Given this list of marker genes Adam1b, Ct55, Ctnnb1, Piwil4, Spem1, Rnase9, Meiosin, Mfsd14a, Prss43, Nanos3, Ska1, Mir449b, Pcyt1b, Drc1, Slc26a6, Pdilt, Amh, Ddx25, Rfx2, Crkl, Gm20843, Xlr4c, Bcl2, Ehmt2, Gnasas1, Gm1993, Gm10488, Lztfl1, Tug1, Inhbb, Tdrkh, Spata25, Hsf1, Pla2g4a, Zfp830, Ubr2, Bcap31, Wdr48, Bsg, Ednra, Armc3, Gm21294, Patz1, Ift20, Fxr1, Mov10l1, Gm2012, Txndc2, Cabyr, Sebox, Cntln, Gm20824, Eed, Rnf151, Catspere1, Hoxa10, Tmem203 (transmembrane protein 203), Eif2s2, Gm21760, Crtap, Tsix, Ybx2, Nr6a1, Catsperz, Cfap97d1, Sox17, Nr5a2, Ap3b1, Usp26, Serpina5, Fbxo24, Tspan8, Pou4f2, Nr0b1, Stau1, Majin, Sox3, Dnah1 (NCBI Gene Id 630521), Wdr77, Mns1, Efcab9, Wnt4, Nectin2, Ccdc33, Pafah1b3, Ropn1l, Bax, Afp, Zscan2, Pgr, Mycbpap, Lrrc46, Gm28961, Oca2, Slc4a2, Bmp8b, Sycp2, Yif1b, Prss37, Marf1, Hadh, Gorasp2, Spag8 (sperm associated antigen 8), Tut7, Cldn11, Golga3, Alkbh5, Tesk1, Bcas2, Asz1, Garin2, Ncaph, Ghsr, Gm21095, Cetn2, Morc1, Ift56, Nodal, Gm10230, Zfp541, Xrn2, Fmn2, Sohlh1, Xlr3c, Src, Igf1, Ttc12, Khdrbs1, Pabpc1l, Rbm46, Bmp4, Sstr1, Nanos1, Kit (KIT proto-oncogene receptor tyrosine kinase), Shb, Zcwpw1, Sec23ip, Kdm2b, Ctsl, Syce3, Celf3, Pik3ca (NCBI Gene Id 70742), Trim75, Sry, Shbg, Lrguk, Prmt7, Gal3st1, Tgfb1, Mael, Mcm9, Tle3, Prnd, Dnaaf3, Rhbdd1 (rhomboid domain containing 1), H1f7, Cadm1, Cip2a, Etv5, Cdc25c, Cabs1 (NCBI Gene Id 70977), Cit, Zmynd15, Ddx3y, Gm28102, Xlr3a, Pgm3, Trp63, Gata4, Mettl14, Sppl2c, Fkbp6, Pln, Stau2, Sod1, Epc1, Gopc, Semg1, Septin4, Cimap1a (NCBI Gene Id 69287), Smad5, Nup62, Gsr, Cntd1, Dicer1, Sgpl1, Foxj2, Tdrp, Tyro3, Ubb, Rab1a, Ndc1, Mcm8 (minichromosome maintenance 8 homologous recombination repair factor), Nppc, Abhd2, Bltp1, Klhl10, Adam7, Dhh, Rbx1-ps, AU040320, Pde4d, Txndc8, Rln1, Zdbf2, Prdm9, Atrx, Csnk2a2, Mecp2, Pxt1, Rad51c, Gm6121, 3830403N18Rik, Dpcd, Ggnbp2, Kcnq1ot1, Gm773, Cnbd2, Mtor, Oosp2, Mybl1, Meiob, Cib1, Airn, Cdkn1c, Spata2, Foxa3, Herpud2, Oas1d, Tle6, Zp3, Tcp11x2, Xlr4b, Six5, Dcaf13, Yy1, Gm21858, Mea1, Bik, Cylc2, Izumo3, Map7, Calr3 (NCBI Gene Id 76879), Hpgd, Axl, Npr2, Qki, Gm38999, Wnt3, Chn2, Axdnd1, Dld, Ube2b, Pnldc1, Sstr3, Psme4, Cfap119, Ptk2b, Ctcf, Ccr6, Clock, H2bc1, Ptx3, Tmprss12, Neurl1a, Adam24, H1f9, Hoatz, Clgn, Svs3a, Klc3, Tnfaip6, Gm20870 (predicted gene, 20870), Dhx36, Washc5, Odf4, Ccdc146, Meioc, Skil, Xlr4a, Fancl, Rgn, Zfp42, Spin2c, Armc12, Poc1b, Gm2030, Paqr5, Slc26a8, Mas1 (MAS1 oncogene), Kat5, Septin7, Sirt2, Arid4b, Dnali1, Mertk, Cylc1, Ythdf2, Mcmdc2, Sly, Kat8, Vps13b, Ttc21a, Pde5a, Tssk4, Rspo1, Garin3, Spdya, Syne1, Ihh, H3f3b, Dpy19l2, Catsper1 (NCBI Gene Id 225865), Adrm1, Il18, Ggt1, Smad4, Atp2b4, Cfap54, Slc25a31, Cfap206, C2cd6, Tnp2, Pias1, Cdc25b, Atp1a4, Vipas39, Spmip6, Igf2r (insulin-like growth factor 2 receptor), Lgr5, Slc26a3, Rimbp3, Tuba8, Septin2, H2al2a, Fancg, Inhba, Kif18a, Dnmt3a, Scmh1, Tcp11, Rnf2, Ccna1, Tslrn1, Agfg2, Gm21996, Ddx20, Spata24, Bbof1, Setx, Inpp5b, Insl6, Garin1a, Rara, Hsf2, Snrpa1, Tmem119, Spag4, Wt1, Tmem232, Pafah1b2, Immp2l, Akt1, Fndc3a, Tssk5, Xist, Cfap44, Tlk2, Dazap1, Spag6 (NCBI Gene Id 381350), Fancd2, Mir449a, Chtf18, Hoxa9, Krt9, Ccnb1, Dnd1, Strbp, Rnf8, Misfa, Gm28870, Ppp1cc (NCBI Gene Id 627816, protein phosphatase 1 catalytic subunit gamma), Nkd1, Cfap70, Adam25, Septin14, Gm5935, Racgap1, Gsk3a (glycogen synthase kinase 3 alpha), Garin4, Fst, Sun5, Cyp26b1, Herc2, Btg1, Atm, Zbtb16, Celf1, Mroh2b, Tsga8, Ift81, Prm3 (NCBI Gene Id 407832), Spata6l, Prkaca, Rai14, Ptch1, Mir449c, Zfp296, Spin4, Notch1, Actl7a, Tssk6, Ddias, Hsf5, Chd5, H1f6 (NCBI Gene Id 57283), Tut4, Slco4c1, Meg3, Usp42, Tesmin, Mta2, Spatc1l, Dnaja1, Txnrd3, Gm20911, Ttll5, Apob, Tex19.2, Agfg1 (ArfGAP with FG repeats 1), H2ax, Garin1b, Rec114, Zmiz1, Spata46, Herc4, Ttll1, Styx, Ctcfl, Lep, Spin1, Rbx1, Gm7958, Cep128, Larp7, Rsph1, Ccdc159, Asb17, Ace, Zfp39, Zscan21, Ttll3, Gm4297, Zglp1, Ccnb1ip1, Selenof, Sun1, Lgr4, Hspa1l, Pla2g3, Bcl6, Eqtn, Ska3, Gm20736, Uchl1, Dmrt1, Gm5934, Ythdc1, Ptgdr2, Zfp37, Armc2, Psma8, Ros1, Ccnyl1, Odf2, Tpgs1, Kctd19, Spef2, Ift27, Catsperg2, Tex15, Msh6, Spire2, Hexb, Lamp1, Hfm1, Acrbp, Ccin, Cfap61, Tex19.1, Gm29866, Fbxw11, Meikin, Gm20817, Brca2 (breast cancer 2, early onset), Sox9, Agt, Bcl2l11, Paip2, Acox1, Zmynd12, Hook1, Ska2, Ctdnep1, Ica1l, Gm29554, Zpbp2, Spag16, Gm20820, Gsk3b, Mei1, Hspa2, Tm9sf5, H1f1, Ankrd49, Ybx3 (NCBI Gene Id 56449), Zfp628, Shcbp1l, Hoxa11, Galnt3, Dmrtc2, Suv39h2, Pmfbp1, Fshb, Sfmbt1, Prss44 (serine protease 44), Rps6kb1, Arid4a, Tial1, Trp53 (NCBI Gene Id 22059), Fancf, Pcsk4, Dedd, Bsph2, Vdac3, Mast2, Cenpe, Mei4 (NCBI Gene Id 75033), Lin28a, Calr, Tbc1d20, Kdm5a, Mamld1, Cnr1, Morc2b, Dcaf17, Bmpr1b, Fbxo5, Aspm, Hmgb2, Prok2, Jam3, Adamts2, Nicol1, Rps6, Hps1, Nek1, Foxc1, Msh2, Ptn, Slc19a2, Spaca1, Sycp3, Kmt2b, Bmp8a, Cfap47, Tmf1, Adgb, Etv6, Pdcl2, Gm20890, Cftr, Spata22, Gamt (NCBI Gene Id 14431), Pde3a, Limk2, Gpx4, Mmp19, Calca, Alms1, Ddx4, Catsper3, Pygo2, Kdm3a, Mir34b, Galntl5, Xlr, Rps6ka2, Xlr5c, Spire1, Cep131, Defb37, Zfp57, Gja10, Zfp449, Ndc80, Angpt2, Ube2j1, Arrdc5, Akap4, Cep57, Ccdc63, Ovol1, Nlrp14, Mkrn2, Frey1, Fanca (NCBI Gene Id 52324), Cfap91, Brip1, Ropn1, Pum1, Acvr2a, Orc4, Mir34c, Ccdc42, Spocd1, Spinkl, Pax5, Brme1, Cxcl12, Odad3, D1Pas1, Zar1, Magoh, Kash5, Ezhip (EZH inhibitory protein), Hpgds, H19, Mlh3, Tssk1, Jag2, Gm29276, Terb2 (NCBI Gene Id 74401), Catsperd, Gm5169, Nobox, Tsnax, Zfx, Rgs2, Gm21627, Cnot7, Pgam2 (NCBI Gene Id 56012), Top2a, Dnmt3l, Bckdk, Bbs2, Boll, Ing2, Ak7, Spem3, Tdrd1, Eif4g3, Catsper2, Sox8, Prdm1, Cfap57, Rnf114, Dazl, H2aj, Parp11, Gjb3, Trim28, Ccnb2, Tex14 (testis expressed gene 14 intercellular bridge forming factor), Fancc, Ntrk1, Fscn3, Tgfbr1, Catspere2, Nphp1, Sirt1, Spag17, Iqcn, Zpbp, Pank2, Spata6, Pacrg, Prm2, Mycn, Morn2, Edn2, Mastl, Fsip2, Cfap43, Nos2, Cdyl, Tdrd6, Nme5, Xlr5b, Prdm14, Creb3l4, Edn1, Slc22a16, Hsf2bp, Ccno, Spag6l, Gdf9, Gtsf1, Sbf1, Foxj3, Fosl1, Spink2, Ccdc34, Actl9, Tex11, Slirp, Adig, Ptgds, Spmap2, 1700102P08Rik, Rnf17, Cfap52, Dmxl2, Bsph1, Ift25, Smchd1, Tdrd12, Kdm1b, Gas2, Insl3, Cfap69, Ccdc62, Nanos2, Msh4 (mutS homolog 4), Spink1, Ncaph2, Ccdc38, Acsbg2, Tbc1d21, Diaph2, Itgb1, Mcidas, Adamts1, Fer, Acvr1, Prm1, Lrrc8a, Fignl1, Jam2, Gm28919, B4galnt1, Sos1, Ereg, Paqr8, Pld6, Htt, Ggn, Msh5, Svs3b, Katnal1, Stk33, Bag6, Cul4a, Adamts16, Spata19, Nr2c2, Ccdc87, Hrob, Tnp1, Ddx3x, Zfp41, Xlr5a, Slc9a8, Dnmt3b, Foxo3, Bcl2l1, Bmal1, Npm2, Adam26a, H3f3a, Ndn, Gm28510, Rad18, Zar1l, Meig1, Slc9c1, Slc22a14 (NCBI Gene Id 382113), Cntrl, Garin5b, Slxl1 (Slx-like 1), Adcyap1r1, Mlh1, Washc1, Sass6 (SAS-6 centriolar assembly protein), Paqr7, Ercc1, Zc3h14, Cdk16, Gnas, Catsper4, Iqcg, Spata31, Bnc1, Nme8, Aurka, Spmip7, Oog1, Adcy10, Pfn4, Mgat4d, Poc1a, Ttll8, Ssty1, Gm28576, Tdrd7, Pygo1, Kmt2d, Sycp1, Aff4, Tbata, Spata20, Fsip1, M1ap, Trip13, Crem, Tdrd9, Garin5a, Ythdc2, Afg2a, Sstr2, Taf7l, Ago4, Nos3, Tppp2, Osbp2, Brdt, Tesk2, Sox30, Bscl2, Stk11, Mst1, Atat1, Sgo2a, Catsperb, Pithd1, Spata16, Cfap65, Bbs4 (Bardet-Biedl syndrome 4), Iqcf1, Spata9, Cfap58, Klf17, Prkg1 (NCBI Gene Id 381235), Ttk, Piwil2, Rbp4, Ccdc136 (NCBI Gene Id 70878), Rpl39l, Cyp51, Drc7, Wipf3, Piwil1, Hmga1, Sufu, Lsm14b, Wee2 (WEE1 homolog 2 (S. pombe)), Neurl4, Pebp1, Utp14b, Spo11, Grb14, Prss42, Ppp2r1a, Cxcr4, Ar, Odf1, 1700013H16Rik, Gm14525, Phc2, Tbpl1, Cfap157, Tnk2, Fam209, Rpl10l, Gm21117, Arhgap33os, Rb1, Shisa6, Nsun2, Gmnc, Cox7b2, Cfap221, Iftap, Prdx4, Fshr, Dmc1, Dnhd1, Gk2 (NCBI Gene Id 14626), S100a11, Dzip1, Defb1, Topaz1, Nup210l, Rad23b, Cfap53, Mdk, Gm5168, Smad1, Lrrk2, Rad21l, Rxfp2, Scaper, H3f4, Gm1140, Stra8, Septin6, Tssk2, Plcb1, Hormad1, Nrip1, Adad1, Plekha1, Mkks, Zfy2, Gm21865, Mettl3, Sohlh2, Adad2, Vps54, Cabcoco1, Pten, Taf4b, Tsnaxip1, Plk1, Siah1a, Dlec1, Ggnbp1, Slx, Il1a, Adam18, Figla, Septin1, Xlr3b, Gmcl1, Zfp148 (zinc finger protein 148), Btbd18, Atn1, Btbd35f1, Hmga2, Pafah1b1, Ssh2, Rhox8, Prss21, Kitl, Mos, Nkapl, Tssk3, Gli1, Upf3a, Tdrd5, Zfp35, Rec8, Tarbp2, Ift88, Cxadr, Rsph6a, Gja1, Gpr149, Iho1, Spata32, Lhcgr, Fhad1, Ddb1, 4930447C04Rik, Eif2s3y, Mmp2, Akap9, here is a description of the gene set: The generation and maintenance of gametes in a multicellular organism. A gamete is a haploid reproductive cell. Mouse Gene Set: GOBP_GAMETE_GENERATION studied in species Mus musculus